Given this list of marker genes Gja5, Acvrl1, Has2, Zmiz1, Ptch1, Hand2, Wnt16, Ovol2, Ube4b, Npy1r, Sos1, Pim1, Nrp1, Cav3 (caveolin 3), Wnt5a, Alpk2, Trp53 (NCBI Gene Id 22059), Fkrp, Ankrd1, Ift88, Hif1a, Id2, Tbx19, Sufu, Smad3, Tgfbr2, Egln1, Ednra (endothelin receptor type A), Mylk2, Insr, Tbx1, Rnls, Bmp5, Kdm6a, Cfc1, Prickle1, Notch2, Heyl, S1pr1, Rbpj, Zfpm2, Notch1, Zmpste24, Zfpm1, Fzd1, Myl3, Tnnt2, Myh6, Gata5, Wnt11 (wingless-type MMTV integration site family, member 11), Jun, Mir20a, Dvl1, Aldh1a2 (aldehyde dehydrogenase family 1, subfamily A2), Robo2, Dll4, Tbx5, Adamts1, Megf8, Slit2, Trex1, Ncor2, Ift172, Snai1, Fgfrl1, Mef2c, Nsd2, Dnaaf1, Folr1, Tpm1, Angpt1, Cpe, Srf, Ccdc103, Rtn4, Fgf8, Mks1, Mir452, Pdcd4, Eya1, Nodal, Axin2, Kat6a, Gata3, Epo, Flrt2, Col2a1, Spry1, Rnf207, Arl13b, Wnt3a, Robo1, Bmp4 (NCBI Gene Id 12159), Dsp, Lrp2, Col11a1, Olfm1, Naglu, Tab1 (TGF-beta activated kinase 1/MAP3K7 binding protein 1), Lefty1, C2cd3, Nrg1, Wnt2, Foxh1, Pds5a (PDS5 cohesin associated factor A), Dvl2, Acvr1 (NCBI Gene Id 11478), Dvl3, Myl2, Gaa, Tgfb3, Nkx2-5, Ilk, Dkk1, Fzd2, Slc8a1, Kcnj8, Smarca4, Tgfbr1, Fkbp1a, Bmpr1a, Mir1a-2, Mesp1, Col5a1, Adgrg6, Greb1l, Hand1, Nfatc1, Adprhl1, Abcc9, Smad7, Tbx3, Klk1b1, Fgf9 (NCBI Gene Id 252883), Foxn4, Sox4, Crkl, Ccm2l, Gng5, Ihh, Vegfa (NCBI Gene Id 22339), Arid2, Stil, Snai2, Tgfbr3, Fat4, Eva1a, Foxc2, Prox1 (prospero homeobox 1), Ttn, Nos3, Ift52, Thbs1, Atf2, Smad4, Rbm15 (RNA binding motif protein 15), Med1, Xirp1, Shh, Fgfr2, Mir19a, Nog, Pbrm1, Sox9, Ccn1, Fhl2, Adamts5, Flna, Psen1, Mdm4, Lemd2, Bmpr2, Mrtfb (myocardin related transcription factor B), Foxf1, Epor, Msx2, 3425401B19Rik, Dicer1, Dchs1, Sema3c, Asb2, Npy2r, Tgfb2, Hes1, Eng, Tbx2 (T-box 2), Cluap1, Gsk3a, Bmp10, Asxl1, Ryr1, Ryr2, Tgfb1, Yap1, Ccdc39, Ppp1r13l, Plxnd1, Emp2, Sox17, Cdc42 (NCBI Gene Id 12540), Tnni1, Ctnnb1, Setdb2, Vangl2, Edn1, Msx1, Mir17, Mtor, Ift57, Pkp2, Tek, Gja1, Tmem100, Synpo2l, Tfap2a (NCBI Gene Id 21418), Tmed2, Sfrp2, Ccdc40, Ankrd11 (ankyrin repeat domain 11), Noto, Cplane2, Chd7, Smad6, Nrp2, Bmp7, Hand2os1, Hey1, Smarcd3, Ephb4, Slit3, Heg1, Mir18, Rbm20, Dnah11, Pitx2, Kdm2a, Gata6, Myh7, Aplnr, Cert1, Ahr, Gata4, Efna1 (NCBI Gene Id 99598), Npy5r, Pcdha9, Rxra, Lbx1, Bmp2, Rbp4, Tnnc1, Sirt6, Mir92-1, Twist1, Adamts19, Cited2, Nipbl (NIPBL cohesin loading factor), Pkd2, Nphp3, Rac1, Mib1, Xirp2 (xin actin-binding repeat containing 2), Foxc1, Tnni3, Mdm2 (NCBI Gene Id 69330), Asxl2, Dll1, Pou4f1, Tcap, Six1, Tbx20, Ext1, Nedd4, Smo, Sox11, Lrp6, Eln, Dlc1 (deleted in liver cancer 1), Zic3, Tead2, Sec24b, Sav1, Shox2, Mical2, Uty, Smad2, Isl1, Htr2b, Dag1 (NCBI Gene Id 13138), Mybpc3, Actc1, Tead1, T, Hey2, Mesp2, Ptcd2, Ly6e, Grhl2, Kif3a, Jag1, Parva, Mir19b-1, Adam15, Dhrs3, here is a description of the gene set: species: Mus musculus Mouse Gene Set: GOBP_HEART_MORPHOGENESIS The developmental process in which the heart is generated and organized. The heart is a hollow, muscular organ, which, by contracting rhythmically, keeps up the circulation of the blood.